Given this list of marker genes HEBP2, DNAJC15, UBE2G2, POLR2I, MED31, MRPL41, MRPL45 (NCBI Gene Id 84311), CNOT9, RHOQ, CLNS1A, PBX2, CLCN5, SMAD4, C1orf35, WASF2, FDFT1, IRF2BP1, C19orf53, TFDP1, PPAN, SLC41A1, PPBP, NCBP1, TSR2 (NCBI Gene Id 90121), RPS14, HDAC6, PEX16, RALB, PTGS1, QNG1, SACS (NCBI Gene Id 26278), EIF5, HERPUD1, MNS1, TPCN2, AAMP, C15orf39, AAGAB, MCFD2, NAF1, CPEB2, TNFAIP8L1, YIF1A, FKBP15, THAP11, PMPCA, ORC5, LDAH, TRMT10C, CHFR (NCBI Gene Id 56732), COX6A1, THBS1, TM9SF3, ZNF574, PIP4K2C, BUD13, KDM2B, PRXL2B, PAGR1 (NCBI Gene Id 79447), ANKS3, PPP6R2, RAMP2, GTF2H3, GOLPH3L, TADA1, PAX3 (NCBI Gene Id 5077), GATC, OARD1, TAGLN, HSPA14, PRKRIP1, PHF12, WRAP73, YY1, ARMC1, ZFP36L2, SS18L2, MRPS34, LMNB2, SMC3, ITPA, ENTPD4, ZFYVE19, ZNF410, B4GALT1, FASN, TMEM53, UTP11, GTF3C4, COL1A2, HS1BP3, ERAS, RSPRY1, FAM118A, ARAP1, ZBTB7A, ING2, RAB11FIP5, PRUNE1, ADAMTS4, SF3A1, PRPF39, COQ8B, CHRNB3, PPP2CA, YARS1, SMARCD2 (SWI/SNF related, matrix associated, actin dependent regulator of chromatin, subfamily d, member 2), SARAF, DGUOK, CXCR4, MRPS26, DOK3, GON4L, CCDC80, MBNL1, TMEM126A, KCNN4, ARL14EP, CLBA1, CD300LF (CD300 molecule like family member f), CD2BP2, ELOVL1, SRM, RNF20, UBTF, SYS1, ASXL1, TLR1, IMP4, HS6ST1, METTL3, EIF4A3, HIF1A, SLC16A1, MTERF4, MTIF2, CCT2, KRTCAP2, RMND5A, NDUFB2, PXMP4, HNRNPC, PNN, MT2A, NTPCR, CEP20, LPXN, FAM98C, UMPS, PLOD1, PDCD7, ELOF1, CCN2, PELO, LTBR, VAMP1, FYN, ATF1, ATAD3A, RIC8A, CREBZF, ZDHHC16, UBALD1, LCMT2, ARHGAP45, ESR2, MORF4L1, BLVRA, FLVCR2, RPA2, LRRC8A, AATF, PEX12, LY96, NEAT1 (nuclear paraspeckle assembly transcript 1), POLE3, ID3, MRRF, GFER, B9D2, EPB41L3, COL5A1, MLYCD, THYN1, TMEM214, ZSCAN26, USP34, PIGH, DHX57, ARL8B, TMEM14C, S100A8, SPPL3, CASKIN2 (CASK interacting protein 2), SEC11A, DUS1L, ZNF35, WDR83, EFHD2, MRC1, here is a description of the gene set: from publication Qualls JE, Neale G, Smith AM, Koo MS, DeFreitas AA, Zhang H, Kaplan G, Watowich SS, Murray PJ (PMID 20716764) Genes down-regulated in macrophages after M. bovis BCG infection: 24h versus 48h. Human Gene Set: GSE22935_24H_VS_48H_MBOVIS_BCG_STIM_MACROPHAGE_DN Nitric oxide (NO) produced by macrophages (MØs) is toxic to both host tissues and invading pathogens and its regulation is therefore essential to suppress host cytotoxicity. MØ arginase 1 (Arg1) inhibits NO production by competing with NO synthases for arginine, the common substrate of NO synthases and arginases. Two signal transduction pathways control Arg1 expression in MØs. First, a MyD88-dependent pathway induces Arg1 in intracellular infections, while a second Stat6-dependent pathway is required for Arg1 expression in alternativelyactivated MØs. We found that mycobacteria-infected MØs produce soluble factors that induce Arg1 in an autocrine-paracrine manner via Stat3. We identify these factors as IL-6, IL-10 and GCSF. We further establish that Arg1 expression is controlled by the MyD88-dependent production of IL-6, IL-10 and G-CSF rather than cell intrinsic MyD88 signaling to Arg1. Our data reveal the MyD88-dependent pathway of Arg1induction following BCG infection requires Stat3 activation and may result in the development of an immunosuppressive niche in granulomas due to the induced Arg1 production in surrounding uninfected MØs studied in species Homo sapiens